The following is a description of a gene set: from publication Chevalier N, Jarrossay D, Ho E, Avery DT, Ma CS, Yu D, Sallusto F, Tangye SG, Mackay CR (PMID 21471443) Genes up-regulated in comparison of naive CD4 T cells versus CD4 CXCR5+ T cells. Human Gene Set: GSE26928_NAIVE_VS_CXCR5_POS_CD4_TCELL_UP studied in species Homo sapiens, and this is the list of marker genes: ZIC4, SLC7A6OS, GGTLC1, ZNF815P, ELP5, MAP3K3, DIP2B, HPGD, PLCL1, COQ8A, CCDC88B, DHDH (NCBI Gene Id 27294), ATPSCKMT, MTMR8, H6PD, EGLN2, CUX2, HSBP1L1, C19orf12, POLL, MTAP, TRPV1, BBS2, ACVR1C, AIP, DSC3, TAF1L, GJB5 (NCBI Gene Id 2709), PEX11B, FBXW4, WNT7B, KCTD17, MRPL43, ACBD4, NPHS1, ATXN10, LCDR, WDR88, BTN3A2, MRFAP1L2, KRT32, FAM220A, EPB41, TMCO4, ALAD, SATB1, SNN, LINC01588, CFAP418, ZNF541, EEA1, TMEM38B, HNRNPA2B1, TMEM168, FRMD7, ASIC4, CIAPIN1, THNSL1, SPPL2B, CDIPT, CYP4X1, NKIRAS2, ZSCAN18, ENGASE, CFAP57, PAX5, ACTN1, C8orf58, ANKS4B, KLK6, LEF1-AS1, SSBP2, KATNIP, ARL6IP4, MRNIP, LINC00205, LINC01193, IKZF1, PDE7A, POLR3C, PNPLA7, DNAI3, ZBTB4, REEP6, COL18A1, NUCKS1, PSKH2, BCDIN3D, GPALPP1, FXYD5, PTCH2, LINC01550, CDKN2D, RAB33A, AIRIM, NAP1L4, ACTG1P17, ATF7IP2, DENND5A, CCR7, MYB, ATRAID, CFAP69, FBXW8, CITED4, LACTB2-AS1, ALKBH7, TMEM204, SLC4A5, MDS2, ADGRA3, RNF175, PHYH, NME3, FOXN3, PDE7B-AS1, SAMD9L, TTLL1, MRTFB, MFSD4A, SIRT3, ENSG00000284691, FMC1, NOG, ZBTB7C, H2BC1, GSAP, AHSA2P, PSMB8, PAAF1, GUCY2C, GXYLT1, SLC12A3, BRSK2, RBM7, HOXA6, FHIT, STARD8, NAA80, SLC25A38, ERC1, TPRG1L (tumor protein p63 regulated 1 like), PRKCA, RRAGB, KLHL11, UBXN10, RNASEH1-DT, PIP4K2B, MAP2K6, ZNF705G, HEMGN, NPM3, SLC25A11, FUNDC2, CCDC63, TDO2, TRIM44, SLC5A4 (solute carrier family 5 member 4), UNKL, MAD2L1BP, WDR7, CCDC65, SEC31B, NAIF1, MUC19, PIK3R2, RNF20, CMKLR1, TIMM13, APEX1, NARS2, CBR1, KCNA4, SYTL1, FHL1P1, VSTM4, KAT2A, BET1L (NCBI Gene Id 93155), TBP, POP5, TMEM243, MPI, DGKA, HJV, ATG10, ZNF512, MAP4K4, CSF2RA, EXOSC7, LRRC41, C2orf92, SGSM3, ZNF224, NUDCD3, ENTREP2 (NCBI Gene Id 23359), FAU, LRRC3